The following is a description of a gene set: electronically inferred by orthology from the curated human pathway part of: Coagulation pathway Reactome Pathway: Initiation of coagulation cascade studied in species Mus musculus This event has been computationally inferred from an event that has been demonstrated in another species.<p>The inference is based on the homology mapping from PANTHER. Briefly, reactions for which all involved PhysicalEntities (in input, output and catalyst) have a mapped orthologue/paralogue (for complexes at least 75% of components must have a mapping) are inferred to the other species., and this is the list of marker genes: F10, Gpc3, F8, Sdc1, F2 (coagulation factor II), F9, F7, Pros1, Gpc2, Sdc3